Given this list of marker genes NOX1, COL5A1, TMEFF2, TGFB2, AR, here is a description of the gene set: Human Gene Set: GOBP_INTEGRIN_BIOSYNTHETIC_PROCESS species: Homo sapiens The chemical reactions and pathways resulting in the formation of integrins, a large family of transmembrane proteins that act as receptors for cell-adhesion molecules.